Given this list of marker genes Abca8b (ATP-binding cassette, sub-family A member 8b), Abcc2, Abcc6, Slc47a1, Abcc3, Slc37a3, Abca3, Abcb11, Slc19a1, Abcc4, Tmem30a, Atraid, Abcb4, Slco1b2, Atp8b1, Abcc1, here is a description of the gene set: Mouse Gene Set: GOBP_XENOBIOTIC_TRANSMEMBRANE_TRANSPORT The process in which a xenobiotic, a compound foreign to the organism exposed to it, is transported across a membrane. It may be synthesized by another organism (like ampicilin) or it can be a synthetic chemical. species: Mus musculus